Given this list of marker genes Ndufa10, Ndufb11b, Timm21, mt-Nd2, Ndufa13, Ndufb10, Tmem186, Ndufaf2, Ndufs8, Ndufaf3, Ndufb4c (NADH:ubiquinone oxidoreductase subunit B4C), Ndufb5, Ndufab1-ps, Ndufs1, Ndufb7, Foxred1, Ndufaf8, mt-Nd5, Ndufs6, Ndufb1, Ndufa3, Ndufa9, Ndufaf7, Tafazzin, mt-Nd1, Ndufs4, Lyrm2, Ndufb4b, Ndufs3, Aifm1, Ndufaf6, Ndufa11b, Ndufaf1, Oxa1l, Nubpl, Ndufa6, Bcs1l, Ndufc2, Ndufb11, Ndufa8, Ndufb2, Ndufaf5, Dmac1, Ndufb8, Ndufa1, Ndufs5, Ndufb9, mt-Nd4, Ndufb3, Ndufab1, Ndufs7 (NADH:ubiquinone oxidoreductase core subunit S7), Tmem126b, Ndufa11, Ndufb6, Ndufs2, Acad9, Ndufa2, Ndufc1, Dmac2, Ndufb4, Ndufaf4, mt-Nd6, Tmem126a, Ndufa5, Timmdc1, here is a description of the gene set: Mouse Gene Set: GOBP_NADH_DEHYDROGENASE_COMPLEX_ASSEMBLY species: Mus musculus The aggregation, arrangement and bonding together of a set of components to form an NADH dehydrogenase complex.